Given this list of marker genes CES1, BASP1, H2AX, RNF19B, TBC1D13, SQSTM1, OSGEPL1, UTP6, HERC5, BEGAIN, TMEM39A, ATP11A, TMEM176A, DPP4, P2RY6 (pyrimidinergic receptor P2Y6), TCL1B, HEG1, ARHGAP22, SERPINE1, OAS1, COQ10B, CSTA, LORICRIN, TXNRD1, IFI6, RMC1, STAP1, FANCE, LDB1, SLCO3A1, INAVA, CCL1, IFITM3, PODXL2, BAALC, REL, TBRG4, DEPP1, CD200, CSF1, XAB2, NUP205, MLLT11, CCR7, MARCKSL1, TGFA, TOR1B, RND3, SP140, RFTN1, ISG20, CCL5, LILRA4, LIMK2, HTR1A, PBXIP1, PPA1, TNFRSF4, STOM, MRPL49, EREG, RUNX3, YLPM1, TRIB1 (tribbles pseudokinase 1), RAB8B, IGFBP3, VPS8, RUFY3, SIK3 (NCBI Gene Id 80236), RFX5, TNIP1, LRRFIP2, ZNF81, MS4A1, LGALS3BP, CD38, IFI44, HARS1, HSD11B1, CFB, IDO1, SLC35E1, DRAM1, RSAD2 (NCBI Gene Id 91543), GABARAPL2, GADD45B, SPTLC2, IL12B, ALDH2, FSCN1, SLAMF1, PSME2, STAT2, NQO1 (NAD(P)H quinone dehydrogenase 1), FILIP1L, SOCS2, CRISPLD2, MAMLD1, SSX7 (SSX family member 7), MMP7, STAT5B, NNMT, GABPB1, CTTN, TRAF3IP3, IFI27, PRKAR2B, CUTC, IFITM2, HHIPL2, TFG, TNFAIP3 (NCBI Gene Id 7128), GADD45G, TAF1A, MEIS3P1, RHBDF2, TSKU, JAK1, KLRK1, IL2RA, CXCL10, FCHSD2, LPAR2, DLK2, IFITM1, CCL19, ADAT1, PGD, EIF4G1, SOD1, CHN1, ARSB, C1QB, SMR3A, IFIT1, H2AP, ABCA5, SERPING1, SLAMF7, CCL4 (C-C motif chemokine ligand 4), APOBEC3G, CFLAR, CLU, BDH2, LAMB3, ALAS1, MDC1, CYP7B1, TNFSF14, INHBA, IRF7, H2BC8, TARS1 (NCBI Gene Id 94887, threonyl-tRNA synthetase 1), VAMP1, PLAUR, AAGAB, ADGRG2, BRD7, NSUN3, MVB12B, NT5E, CCL23, IFIT5, SIGLEC1, MX2, SINHCAF, TLK2, HEXIM1, SEMA4A, MX1, IRF9, PMS2P5, DUSP1, PIM1, ATF3, SERPINA1, ABCC1, POGLUT1, HBEGF, IFIT3, PARP12, ITGA8, CYB5A, KLK11, AIM2, MTMR3, OGFOD1, TWIST1, LAMP3, PPIF, CD80, HCP5, IFI44L, DIPK1A, NFKBIA, PIK3CG (phosphatidylinositol-4,5-bisphosphate 3-kinase catalytic subunit gamma), ISG15, INHBB, VTN, USP11 (NCBI Gene Id 8237), here is a description of the gene set: In the present study we used Affymetrix oligonucleotide microarrays to produce gene transcription profiles for the major leukocyte types in humans. This comprehensive dataset enabled us to not only establish which genes were expressed in each leukocyte type, but also which genes were expressed in each subset after activation. The used of a comprehensive dataset of gene profiles from all the major human leukocyte subsets enabled a novel and powerful means for identification of genes associated with single leukocyte subsets, or different immune paradigms. Human Gene Set: GSE3982_CTRL_VS_LPS_48H_DC_DN Genes down-regulated in comparison of untreated dendritic cells (DC) versus DCs treated with LPS (TLR4 agonist) at 48 h. from publication Jeffrey KL, Brummer T, Rolph MS, Liu SM, Callejas NA, Grumont RJ, Gillieron C, Mackay F, Grey S, Camps M, Rommel C, Gerondakis SD, Mackay CR (PMID 16474395) species: Homo sapiens